Given this list of marker genes MASP1, COL4A2, APOB (apolipoprotein B), SCGB3A2, COLEC12, COL1A2, COL4A1, HSP90B1, COLEC11, APOA1, MSR1, CALR, FTL, COL3A1, MARCO, FTH1, APOE, SCARA5, COL1A1, here is a description of the gene set: species: Homo sapiens Human Gene Set: REACTOME_SCAVENGING_BY_CLASS_A_RECEPTORS Scavenging by Class A Receptors